The following is a description of a gene set: studied in species Homo sapiens Autophagy-vesicle nucleation/elongation/maturation, sequestosome-1-like receptor. Pathway ID: N01716. Pathway type: Reference. Pathway class: nt06532 Autophagy. Human Gene Set: KEGG_MEDICUS_REFERENCE_AUTOPHAGY_VESICLE_NUCLEATION_ELONGATION_MATURATION_SEQUESTOSOME_1_LIKE_RECEPTOR Pathway Definition from KEGG: Ubiquitinated_protein == (SQSTM1,NBR1,OPTN,CALCOCO2,TAX1BP1,WDFY3) == LC3-II, and this is the list of marker genes: UBC, UBB, MAP1LC3B, RPS27A, TAX1BP1, NBR1, MAP1LC3B2, CALCOCO2, MAP1LC3C, OPTN, UBA52, MAP1LC3A, SQSTM1, WDFY3